The following is a description of a gene set: Mouse Gene Set: GOBP_NEGATIVE_REGULATION_OF_MOLECULAR_FUNCTION Any process that stops or reduces the rate or extent of a molecular function, an elemental biological activity occurring at the molecular level, such as catalysis or binding. species: Mus musculus, and this is the list of marker genes: Adipoq, Rpl5, Lyn, Serpinb9g, Sfrp2, Gprc5a, Dffa, Arrb2, Ttc8, Dkk1, Neil1, Parp9, Sirt1, Ceacam1, Mad2l2, Zfp90, Cyp27b1, Cys1, Sox11, Rnf2, Carm1, Csta3, Rwdd3, Pkhd1, Ace2, Calm1, Aurka, Cnrip1, Commd7, Sri, Garem1, Irs2, Serpinb6c, Mdfi, Dnajc3, Bin1, Wwp2, Spock1, Sfrp1, Hpn, Kdm1a, Foxa2, Irak3, Abca2, Msx2, Rgma, Ifng, Apoe, Lilrb4a, Chuk, Epha1, Mvp, Wnk4, Ifi209, Mapk3, Il10, Ifi213, Zc3h12a, Aida, Nolc1, Gla, Prkca, Gckr, Nlrc3, Kcne2 (potassium voltage-gated channel, Isk-related subfamily, gene 2), Usp17le, Brms1, Tnnt2, Spink1, Cep43, Apcs, B2m, Setd6, Cstdc3, Rock1, Serpinb9d, Banf1, Ppp1r12a, Bax, Ifi208, Ppp2cb, Itga4, Smpd1, Erbin, Serpinb1a, Tcf7l2, Camk2d, Cd300a, Kat2b, Dhrs7b, Fbxw7, Ptprf, Grn, Serpinb9b, Oxa1l, Spock3, Gstp1, Ctnnbip1, Pabpn1l, Psen1, Camk1, Hnrnpu, Frmd7, Fbxo5, Nlrc5, Chp1, Met, Gsk3a (NCBI Gene Id 76828), Foxj1 (NCBI Gene Id 15223), Eif4a2, Pla2r1, Tsc1, Rack1, Macroh2a1, Vtn, Hmga2, Gstp-ps, Eif2ak4, Gapdh, Cstb, Calm3, Drd4 (dopamine receptor D4), Cand1, Taf7 (TATA-box binding protein associated factor 7), Prox1, Cdkn1a, Csta1, Kcne3, Twist1, Il7, Lrrk2, Hamp, Park7, Rbck1, Habp4 (NCBI Gene Id 80586), Chmp6, Traip, Paxip1, Cdkn2c, Apba3, Sfrp5, Usp33, Ptprt, Cmklr1, Prdx5, Nqo1, Sln (sarcolipin), Kat6a, Inpp5k, Timp3, Tlr9, Gnaq, Pou4f2, Adarb1, Akap5, Pkn1, Apc, Zfyve28, Cln3, Gzma, Bag5, Ripor1, Pkig, Trim27, Tfip11, Rb1, Serpinb1b, Heg1, Rpl23, Ndfip2, Ins1 (insulin I), Ttbk1, Wfikkn2, Timp2, Esr1, Spry2, Plin5, Timp1, Ptprb, Crbn, Atp2a2, Lilrb4b, Irak1, Gskip, Zfp932, Limk1, Ptx3, Chordc1, Wwtr1, 1810037I17Rik (RIKEN cDNA 1810037I17 gene), Ubash3b, Pim1, Epm2a, Ank3, Atp2a3, Pkd2, Jak2, Tmem132c, Uchl1, Tmbim1, Gpr35, Stfa2l1, Rrp1b, Nek2, Gtf2f1, Rsf1, Mad2l1, Tmbim6, Lats2, Srcin1, Cblc, Bcl3, Nfkbil1, Pin1rt1, Hfe, Phb2, Stmn1, Tmed10, Men1, Ins2, Ndn, Nfatc4, Nfib, Cdkn1c, Cav3, Lats1, Slpi, Serpinb8 (serine (or cysteine) peptidase inhibitor, clade B, member 8), Blvra, Tceal7, Stk38, Nod2, Crhbp, Ltf, Hdac2, Pias2, Inca1, Akt1, Msx1, Btaf1, Angptl8, Nprl2, Tinf2, Cep85, Gopc, Vcpkmt, Prkn, Tnfsf4, Abl1, Cstdc4, Hand1, Rtraf, Adora3, Ptpro, Eppin, Ecm1, Rap1gds1, Flna, Ptgis, Amot, Dtx3l, Nherf1, Coro1c, Pparg (peroxisome proliferator activated receptor gamma), Ccar2, Ttbk2, Myod1, Irak2, Bag2, Cstdc5, Mt3, Efhb, Drd2, Phpt1, Hexim2, Apoa2, Angptl4, Spink5, Fetub, Osr1, Otulin, Midn, Sh3bp5, Spink6, Bbs4, Csta2, Serpinb6e, Tbx6, Hras, Nupr1, Spry4, Cdkn1b, Bmp2, Serpine1, Pin1, Mrln, Gadd45a, Nwd1, Ajuba, Pex14, Dusp3, Psen2, Lef1 (lymphoid enhancer binding factor 1), Serpinb13, Kcnq1, Pim2, Gnb5, Prkcd, Atp2b4, Smim6, Tmigd3, Tfap4, Pdgfb, Ccm2l, Commd6, Zfp36, Myc, Gstp3, Ppm1f, Paqr3, Il1b, Plec, Tigar, Usp7, Stfa1, Spi1, Rcc2, Pla2g10, Pkib, Ubxn1, Map3k10, Acp4, Epo, Ubqln1, Cyld, Serpinb9c, Nf2, Nos3, Psme3ip1, Setd7, Ifi203-ps, Angptl3, Ralgapa1, Mitd1 (NCBI Gene Id 69028), Cox11, Sp100, Usp44, Rgs14, Agrn, Stk39, Mkks, Clec12b, Gba1, Stfa2, Senp2, Klf4, Mapk8, Ppm1e, Crb2, Cttnbp2nl, Xrcc1, Dnaja3, Tut4, Wfikkn1, Ptk6, Ckmt1, Wapl (WAPL cohesin release factor), Gmip, Plscr1, Egln1, Sort1, Lrch1, Trim37, Styx, Kcnab1, Calcr, Nedd4, Trim21, Foxs1, Nosip, Dbndd2 (NCBI Gene Id 99295), Tsc2, Tsg101, Nog, Ptprh, Pdcd4, Smo, Foxh1 (forkhead box H1), Nup62, Prdx3, Xirp1, Stub1, Trib3, Epb41l5, Adgrg3, Cav1, Zgpat, Adar, Cacna1f, Serpinb6d, Dgkh, Thy1 (NCBI Gene Id 21838), Gadd45g, Nr0b1, Ddit3, Trib2, Serpinb9e, Prkar1a, Cdkn2a, Gadd45b, Calm2, Plxnb3, Adgrv1, Apoc3, Mepce (NCBI Gene Id 27978), Rpl11, Prdx2, Slc8a1, Ybx2, Dact1, Tnfaip3, Uri1, Fem1a, Rgs2, Ifi214, Itgb1bp1, Nfkbia, Shh (sonic hedgehog), Nr0b2, Dusp19, Tnf, Gsto1, Twist2, Hhex, Cst3, Tmc8, Hspb1, Ptch1, Cbarp, Tnni3, Npm1, Ndfip1, Commd1, Serpinb6b, Serpinb9, Snca (synuclein, alpha), Tmed2, Dab2ip, Ppara, Spop, Gstm7, Sumo3, Ezh2, Oxsr1, Cdk5rap3, Cyp1b1, Tle5, Cdk5rap1, Akt1s1, Wee2, Cst7, Nes, Prmt2, Qars1, Ifi207, Mapt, Ttc36, Spred1, Fbh1, Pten, Agt, Arrb1, Foxp3, Pias4, Dap, Prkag2, Drd5, Pxk (NCBI Gene Id 52518), Stfa3, Heyl, Id2, Serpinb9h, Nos1 (nitric oxide synthase 1, neuronal), Hyal2, Lhx2, Golga2, Acod1, Sfrp4, Prkch, Trim40, Bhlhe40, Camk2a, Arhgap28, Zfp462, Serpina5, Wnk1, Dusp10, Med13, Dnaja1, Pthlh, Ufl1, Ptpn2, Spink2, Fzd6, Mmp9, Aurkb, Tdg, Tnfrsf4 (tumor necrosis factor receptor superfamily, member 4), Tnks, Socs5, Itgav, Mllt1, Ilrun, Sympk, Itch, T, Pcsk9, Kcnrg, Peli1, Ppp3ca, Dnajb2, Mapk8ip1, Slc8a3, Nr1h4, Mturn, Bscl2, E2f1, Errfi1, Ptprj, Styx-ps, Tex14, Pnkp, Ifit2, Fbxo7, Sik1, Gnl3l, Gpsm1, Zfas1, Mstn, Rps7, Gapdh-ps15, Nppa, Ptpn6, Slc4a1, Notch1, Mtrr, Psmd10, Prkrip1, Taf3, Rasip1, Cln8, Pbx1, Ormdl3, Pycard, Ralb, Hand2, Glis2, Myocd, Serpinb6a, Aim2, Siva1 (NCBI Gene Id 30954), Shb, Gapdhrt, Jun, Eomes, Igf1r, Cd200, Ggnbp2, Atp5if1, Wars1, Grp, Cat, Nedd4l, Dusp7, Cebpg, Tax1bp1, Nr2f2, Itgb3, Gfi1, Larp7, Serpinb1c, Cstdc6, Fmr1, Ikbip, Gemin2, Terf1, Arfgef1 (NCBI Gene Id 226334), Sumo1, Ublcp1, Eng, Kcne1, Gata1, Ptpn22, Reck (reversion-inducing-cysteine-rich protein with kazal motifs), Arl2, Nfkb1, Cpne1, Id1, Pex19, Deptor, Anxa4, Lrp6, Dusp1, Sh3bp4, Nf1, Cast, Ripor2, Nfkbid, Rdx, Rd3, Xcl1, Serpine2, Hamp2, Nlrp12, Pln, Tmem225, Bag4, Actn2, Lrpap1, Ppia, Ddx11, Palm, Hipk3, Mndal, Socs4, Gtpbp4, Fabp4, Traf3, Hey2, Serpinb9f, Id3, Ptpn1, Trib1, Dtnbp1, Ramp3, Havcr2, Dusp22, Ifi206, Ifi203, Apoa1, Ptprc, Slc27a4, Vps25, Adam15 (ADAM metallopeptidase domain 15), Hdac3, Hdac4, Rlim, Lrrc14, Casp3, Casq2, Spry1, Plk1, Gstp2, Lepr, Crtac1, Parp10, Smad7, Terf2, Smyd3, Zfpm1, Dysf, Cactin, Dab2, Ppif (NCBI Gene Id 105675), Pkia, Wfdc6a, Hmgcr, Gapdhrt2, Apoc1, Pura